The following is a description of a gene set: from publication Schlosser I, Hölzel M, Hoffmann R, Burtscher H, Kohlhuber F, Schuhmacher M, Chapman R, Weidle UH, Eick D (PMID 15516975) Cluster 5: genes up-regulated in B493-6 cells (B lymphocytes) by MYC alone or in combination with serum but not by serum alone. Proliferation of higher eukaryotic cells is triggered by the proto-oncogene c-myc (myc), which is induced downstream of a large number of growth factor receptors. Myc, a basic helix-loop-helix leucine zipper transcription factor, transmits growth signals by up- and downregulation of target genes. The importance of Myc in growth control is well established. However, the number of growth control genes requiring Myc as an essential factor for regulation after mitogenic stimulation of cells is not yet clear. Here, we have studied the transcriptional programme of a human B-cell line, P493-6, in response to Myc and serum. P493-6 cells do not express the endogenous myc, nor is it induced by serum stimulation. Proliferation of the cells is dependent upon both the expression of a tetracycline-regulated myc gene and serum stimulation. Using DNA microarrays, expression profiling was performed following stimulation of cells with serum, with Myc, or with both. We observed serum regulation of >genes. A number of these genes were synergistically or antagonistically regulated by Myc. Moreover, we identified >300 Myc-regulated genes that were almost unresponsive to serum. Gene ontology analysis revealed that a high proportion of Myc target genes are involved in ribosome biogenesis and tRNA metabolism. The data support our current notion that Myc is essential for the regulation of a large number of growth-related genes in B cells, and cannot be replaced by other serum-induced factors. Human Gene Set: SCHLOSSER_MYC_TARGETS_AND_SERUM_RESPONSE_UP studied in species Homo sapiens, and this is the list of marker genes: SRSF2, AMD1, NOP2, ILF3, SLC1A5, LMNB2, ATXN10, CCDC86, MYC, RCN1 (reticulocalbin 1), SLC7A5, INTS10, PRMT1, VDAC1, ZNRD2, METAP1, DDB1, PTDSS1, SLC39A14, TSR1, CAMKK2, USP13, FXN, POLR1F, GSPT1, SNRPB (small nuclear ribonucleoprotein polypeptides B and B1), FAM216A, COMT, THOP1, SCAMP1, ZPR1, ATP2A2, ZNF263, PPRC1, LSM7, ODC1, SRP72, GEMIN4, PRR3, CEP68, UCK2, TMED3, ATP1B3, GRPEL1, EIF5B, EIF1AX, BAG1, NME1